The following is a description of a gene set: Human Gene Set: GOBP_MITOTIC_CELL_CYCLE Progression through the phases of the mitotic cell cycle, the most common eukaryotic cell cycle, which canonically comprises four successive phases called G1, S, G2, and M and includes replication of the genome and the subsequent segregation of chromosomes into daughter cells. In some variant cell cycles nuclear replication or nuclear division may not be followed by cell division, or G1 and G2 phases may be absent. studied in species Homo sapiens, and this is the list of marker genes: SCRIB, MIR26A1, FBXW5, MTA3, WEE2, NME6, AFG2B, MTMR3, TRIM35, DPF1, PTPN11, UHRF1, TOM1L1, KIF25, BCL2, BAZ1B (NCBI Gene Id 9031), EPS8, ZWINT, MIR372, PDGFB, UBE2A, ESPL1, EXOC6B, NPM2, ZFYVE19, MIR638, RBM46, SEH1L, FSD1, MIR221, NUDC, CCDC66, MIR208A, MIR15A, TRIM39, CHMP1A, TUBGCP3, MIR519D, NUF2, APP, KAT2B, PPP1CC, CENPI, PTPN6, MIR19B1, CDC7, TUBB8, BRCA2, CDK6, SIK1, DAPK3, MAP9, CHFR, TRIP13, SMARCD1, CCNE2, SMC1A, CNTROB, PSRC1, TUBA3C, NKX3-1, ZFYVE26, E2F8, CCNP, CCSAP, USP37, BCL7C, FHL1, SPTBN1, SETD2, BRSK2, ANKFN1 (NCBI Gene Id 162282), HEXIM2, CCND1, CAMK2A, TUBD1, MIR137, DONSON, BRCA1, TAF10, SPC24, RPA3, MZT1, CHMP4BP1, TUBB2B (tubulin beta 2B class IIb), FZR1 (NCBI Gene Id 8855), CACNB4, APPL1, MEIOC, GJA1, NUP62, STIL, HASPIN, RNF2, EME2, DUSP3, RECQL5, YWHAE, FOXN3, MNAT1, RBL1, TFAP4, NDE1, TUBB, CCNB3, FOXC1, MIR193A, WAC, RNASEH2B, CCNA2, TNKS, MEPCE, STAG1, ZMPSTE24, INS, CRLF3, NOLC1, SAPCD2, ITGB1, BABAM1, BIRC5, CCNG1, CKAP2, PPM1D, TACC2, DDR2, MBLAC1 (metallo-beta-lactamase domain containing 1), TOM1L2, PAFAH1B1, FIRRM, MIR29C, GSPT1, RRM2, UBE2C, CTDSP1, EXOC8, DYNC1H1, PPP1R10, TPX2, CDK14, TFDP3, CCDC8 (coiled-coil domain containing 8), KLHL18, SPAG5, ZNF830, GEM, FBXL7, DBF4B, MSH2, TPD52L1, CHMP4A, AKAP8L, RPRM, PSMG2, CYLD, NSL1 (NCBI Gene Id 96380), ZNF268, KLF11, TAL1, KLHDC8B, ZNF365 (zinc finger protein 365), STAT5A, ACTB, DLGAP5, TUBB3, PIM3, MIR892B, EZH2, RMDN1, FBXO7, KCNH5, PRMT2, SASS6, BTC, SON, SMC5 (structural maintenance of chromosomes 5), GAS1, ATF2, FBXO5, NFIA, RPS6KB1, NCAPH, MAD2L2, CENPJ, CDKN2C, CEP192, SKA2, CLIP1, EIF4EBP1, MIR362, SMARCA2, TMEM14B, CDK2, KLHL22, NHERF1, CDC25C, LRP5, KIF14, DCUN1D3, BCL6, CCNG2, SPRY2, AURKAIP1, ANKLE2, OFD1, PRICKLE1, RTKN, CDC23, CDKN2B, PPP1R9B, ACVR1, USP44, ETAA1, JADE1, KIF23, ID2, ANGEL2, CDK11B, RCC1, FGFR1, BUB1B, EXOC4 (exocyst complex component 4), STMN1, SMARCE1, TRIM36, FAM107A, DUSP1, STK35, CENPA, ECT2, MDC1, CLSPN, DLG1, MYO16, MIR495, ARHGEF10, DDX3X, USP16, GMNN, DCTN2, FOXO4, CTNNB1, RTEL1, SDCBP, PTCH1, SMARCD2, BCL7B, EDNRA, CCNY, BCCIP (NCBI Gene Id 56647, BRCA2 and CDKN1A interacting protein), PKD2, KIF4A, CDKN2D, RPS27L, GEN1, AMBRA1, MIR195, PPP6C, MIR214, CUL2, CDK10, SPAST, AATF, CCNE1, RIPOR2, BRINP2, TNF, HNRNPU, EFHC1, GPSM2, SETDB2, ANKRD17, NSMCE2, LZTS2, HECA, NCAPD2, STAMBP, BRINP3, ACTL6A, NUDT15, EGFR, PHF10, CUL4B, TAOK2, CDC14A, MIR30C2, SPC25, NEK9, CDK4, CCNJ, PIBF1 (progesterone immunomodulatory binding factor 1), GTPBP4, IL1A, CALM1, EXOC3, CENPW (centromere protein W), TBCE, ADAMTS1, SNX9 (NCBI Gene Id 51429), CDC14B, PDGFRB, ANKRD53, MIR16-1, DBF4, MBTPS1, INSR, INCENP, WDR62, PSME3 (NCBI Gene Id 10197), UBE2S, SUN2, SPHK1, EML1, IK, EDN3, KIF20B, TTC19, RINT1, RB1, DNA2, IER3, AIF1, MTBP, ZFP36L1, CDK2AP2, MAP4, PDIK1L, RRM2B, PHOX2B, MYBL1, SMARCD3, TUBG1, SIRT2, NOP53, RBBP8, XRCC3, ZFP36L2, CDCA2, KNTC1, GPSM1 (G protein signaling modulator 1), CLASP2 (NCBI Gene Id 440948), CYP1A1, PPP1R12A, RAD51B, USP2, CHMP5, CALM2, KMT2E, EML3, E2F1, PPME1 (protein phosphatase methylesterase 1), MIIP, BTN2A2, MTMR4, FBXO43, UBA3, MIR451A, RPA2 (NCBI Gene Id 6118), ECD, GINS3, E2F7, SMARCB1, TTN, CEP97, FZD3, CHMP7, AVEN (apoptosis and caspase activation inhibitor), RAB11A, SH2B1, CDKN1B, EGF, CAV2, TTC28, NCAPD3, NIPBL, KCNA5, RAB35, OVOL1, TAOK1, ARPP19, CEP250, EME1, DCDC1, DYNLT3, CCNH, H2BW1, TERT, CDK5RAP3, PLK2, BROX, MUS81, RASA1, UBD, KIF20A, FBXL15, CUL5 (cullin 5, NCBI Gene Id 8065), TTLL12, CHMP4B, SKA3, KIF4B, TPR, AKAP8, PRP4K, POLDIP2, CCNA1, CENPC, BID (BH3 interacting domain death agonist), EREG, ENSA, PTEN, CENPT, SEPTIN6, PBK, AURKA, GNAI1, TUBGCP5, BMP7, KDM8, TCF3 (NCBI Gene Id 6929), NEK6, SNX18, XRCC2, RBL2, CDKN1A, PPP2CA, SMC3, CDKN2A, ARF1, PCNT, REEP4, CENPH, MITD1, RAD9A (RAD9 checkpoint clamp component A), CKS1B, PKD1, MDM2 (MDM2 proto-oncogene), MCM3, ANAPC7, PRDM5, CIB1, MIR29A, TUBAL3, MRE11, DGKZ, LPIN1, LCMT1, MRNIP, SLFN11, DPF2, SENP2, AFAP1L2, MARK3, ABL1, BRD4, TMEM8B, USP29, PCNA, CUL4A, TENT4A, TUBA4A, USP26, ABRAXAS1, SMOC2, ANXA1, PRKCA, CFL1, ERCC2, CCND2, INHBA, TUBA1C, DRD3, USH1C, SETMAR, NCAPG (NCBI Gene Id 64151), DCTN6 (NCBI Gene Id 10671), PLCB1, NDEL1, FOXM1, CHMP6, UBE2E2, DYNC1LI1, CLASP1, FBXW11, SMC4, AZI2, CHAMP1, TK1, ASCL1, CDCA8, ABRAXAS2, RAD21 (RAD21 cohesin complex component), VPS4A, BRINP1, MAP3K20, HECW2, BCAT1 (branched chain amino acid transaminase 1), TAOK3, TGFB1, CENPK, MIR515-1, MAD2L1, DCTN3, AAAS, VPS4B, PKN2 (protein kinase N2), WDHD1 (NCBI Gene Id 11169), SMPD3, HSPA1B, CCNB1, LSM10, KIF18A, ANAPC1, ABCB1, VRK1, RAD51C, WAPL, KIF22, DRG1, XPC, DDB1, KIF11, CTDNEP1, PKHD1, KIF18B, TUBA1B, RGCC, EIF4E, PPP3CA, TACC3, BCL7A, TPRA1, LATS1, LGMN, PPP2R1A, RAD50, CCDC61, THAP1, BANF1, SMARCA4 (SWI/SNF related, matrix associated, actin dependent regulator of chromatin, subfamily a, member 4), CD28, MCM2, MYH10, PHF8, ROCK1, NEK2, CDC27, MCIDAS, FOXG1 (forkhead box G1), PTPA, RAB6C, ASAH2, DIS3L2, PRC1, PPP2R2D, TOPBP1, KIF3B, INIP, BABAM2, SPRY1, TUBB6, TRIM71, PRMT5, PTPN3, FLNA, BAP1, RHOA, ANAPC10, RFWD3, BORA, CCNI2, EIF4G1, POC1A, ARL3 (ADP ribosylation factor like GTPase 3), ERCC3, BRSK1, NAA50, CHMP1B, MIR222, PRKDC, LSM14A, MIR29B1, PTENP1-AS, CDKN1C, NFIB, KHDRBS1, ORC1, ATR, MBTPS2, CTDP1, STOX1, CDT1, FANCD2, TUBB4A, CDKN3, ROCK2, CCNJL, WEE1, NCAPG2, FGF8, RRM1, MCM4, CDK9, CDC25B, ARID1A, GINS1, BOD1, SPART, ZNRD2, UIMC1, MISP, RTF2, KNSTRN, TTYH1, STAG2, CCND3, HSPA1A, CACUL1, RHOC, EDN1, IQGAP3, CUL7 (cullin 7), IGF1, SIRT1 (sirtuin 1), CIT, MIR15B, SIN3A, SPDYA, ATAD5, ARID1B, GBF1, TICRR, RGS14, CDK5RAP2 (NCBI Gene Id 55755), BARD1, LSM11, RANGRF, TFDP1, INPPL1, NEDD1, ANAPC5, CDK7, MIR21, GIGYF2, TADA3, PPP5C, MIR133B, RPL24, SNX33, CENPE, MYB, DNM2, PLK5 (polo like kinase 5 (inactive)), ZW10, HES1, PIM1, CETN2, PHIP, SMARCA5, RNF40, KIF15, DMRT1, USP8, CDK11A, ATM (ATM serine/threonine kinase), CHMP3, TACC1, ANAPC16, PLRG1, KANK2, IQGAP1, PPP2CB, MAEA, PAX6, CHEK2, MIR134, GFI1B, ARF6, RAB11FIP3, TUBA3E, MEIS2, LATS2, TUBA8, NEUROG1, EXOC5, PARP3, IL1B, PSME2, HUS1, SPDL1, PBX1, BUB1, NDP, CTDSP2, DBX2, UBE2I, MUC1, NUSAP1, CKS2 (CDC28 protein kinase regulatory subunit 2), NABP2, TUBGCP4, FAM110A, KIFC1 (NCBI Gene Id 95229), OBSL1, DCTN1, PIN1, EML4, CDC73, YEATS4, TUBB8B, ACVR1B, E2F3, TBCD, CCDC57, NSFL1C, CDC20, ZNF324, TP53, ANAPC15, CUL3, NDC80, CKAP5, POLE, IL10, EPGN, PRKCB, ANLN, ANAPC2, SHB, CCL2, ZC3H12D, CDK1, STK33, DACT1, PLK3, NES, DPF3, RCC2, IGF2, IST1, MAD2L1BP, RANBP1, APPL2, SBDS, ARID2, FGF10, CEP126, INO80, GPNMB, AURKC, BECN1, WRAP73, IQGAP2, CDC16, CUL1, INTS3, HOXA13, CCNO, CDC34, STAT5B, GOLGA2, EXOC2, PKMYT1, NCAPH2 (NCBI Gene Id 96652), BBS4, MIR520H, PRAP1, NAE1, TUBB2A, CHMP2A, KAT5, BUB3, SMC2, E4F1, TUBE1, PBRM1, ZWILCH, RHOB, CDC25A, L3MBTL1, EXOC6, BRCC3, PIM2, ZNF655, NFE2L1, RIOK2, SKA1, EXOC7, GPR132, RFPL1, TM4SF5, REEP3, CEP85, TEX14, RNF20, KNL1, TTK (NCBI Gene Id 7272), JTB, SMARCC2, SPICE1, SKP2, CCNF, FOXA1, HTT, CDK3, SDE2, MYBL2, CENPF, RHOU, ACTL6B, RAN, PDCD6IP, TUBGCP6, NRDE2, DTL, RACGAP1, HDAC3, ANK3, ASNS, ADAM17, LIG1, RPTOR, CHMP2B, WNK1, WNT10B, RAD51, RRS1, ANAPC13, MYC, MAP10, RAE1, NEK11 (NIMA related kinase 11), ANAPC4, NEK4, USP22, HSF1, HINFP, FBXO31, KATNB1, PHF13, NUMA1, MASTL, CDC14C, HUS1B, CHMP4C, EXOC1, TP73, POLA1 (DNA polymerase alpha 1, catalytic subunit), BLM, LIPA, KIF2A, CDCA5, MIR520A, TUBA3D (NCBI Gene Id 150778), CHEK1, SMARCC1, TTL, CPSF3 (cleavage and polyadenylation specific factor 3), NABP1, PINX1, UBXN2B, RAD17 (RAD17 checkpoint clamp loader component), MELK, MIR133A1, TREX1 (NCBI Gene Id 82474), PSME1, ZNF207, ANAPC11 (anaphase promoting complex subunit 11), CDC42, UNC119, YTHDC2, AKT1, CCNI, MAP1S (microtubule associated protein 1S), KPNB1, CALM3, TMOD3, MCM6, NEK3, CTC1, CLTC, MIS12, CUL9, MKI67, CDC6, PDXP, MYH14, RDX, CLTCL1, BMP4, TRIAP1, DYNLT1, TAF2, ILK, RAD9B, NLE1, VCP, NBN, MCPH1, TIPIN, TUBGCP2, APC, KIF2C, CDC45, TUBA1A, PABIR1, TUBG2, CDC26, NEK7 (NIMA related kinase 7), PIAS1, HSPA2, MAPRE1, SYF2, INTS13, BRD7, TUBB4B, TGFA, KMT5A (NCBI Gene Id 387893), PLK1, KLF4 (NCBI Gene Id 9314), HGF, TUBB1, CTDSPL, CCNB2, BTG3, PML, MAD1L1, CEP55, PKIA (cAMP-dependent protein kinase inhibitor alpha), ENKD1, ID4, AURKB